The following is a description of a gene set: Abnormality of hair growth studied in species Homo sapiens Human Gene Set: HP_ABNORMALITY_OF_HAIR_GROWTH, and this is the list of marker genes: KRT71, PPP1CB, KRT25, LPAR6, GTF2E2, ADAM17, LIPH, KRAS, CDSN, RPL21, EDARADD, IFT122, KRT74, KRT86, MAP2K2, TP63, RNF113A, SHOC2, EDAR, EGFR, MAP2K1, KRT81, KRT83, BRAF, GJA1, GJB6, NR2F1, TRPS1, ZFX, CST6, DSG4